The following is a description of a gene set: Binding to DNA that is assembled into chromatin. species: Mus musculus Mouse Gene Set: GOMF_CHROMATIN_DNA_BINDING, and this is the list of marker genes: Foxo3, H1f2, Ruvbl2, Rara (retinoic acid receptor, alpha), Pitx2, Actn4, Hmgn2, Tox, Hmga2, H1f10, Rxra, Wbp2nl, Crebbp, Hdac3, H1f5, Eomes, Myod1, Sbno1, Stat3, Thrb, H1f4, Bap1, Rcc1, Zfx, Pcbp2, Tox3 (TOX high mobility group box family member 3), Zfp125, Thra, Hmgn5, Ep300, Med1, Grhl2, Hr, Wbp2, Gli2, H1f0, Zfp276, Myog, Kdm6b, Zic2, Neurog3, Ahdc1, Uty, Grhl3, Top1, Hsf3, Vax1, Hmgn1, Klf4, Atoh1, Grhl1, H1f8, Foxc2, Sbno2, Nr1h2, Smad3, Nkap, Ctcfl, Cebpa, Sox2, Apex1, H1f9, Sirt6, Rxrb, Kdm3b, Vax2, Insm1, Msl2, Srf, Kdm3a, Pou5f1, Foxo1, H3f3a, Cebpb, Jmjd1c, Xbp1, Pax6, Ezh2, Lemd3, Kdm6a, Hmgn3, Dhx9, Tox4, Gata1, Vrk1, Hdac2, Macroh2a2, Lemd2, Bcl6, Ppargc1a, Zfp692, Per1, Kdm4d, Hcfc1, H3f3b, H3f5, Ddx17, H1f3, Hnrnpu, Suz12, Tbr1, Ctcf, Tox2, H1f6, Kdm5a, Runx2 (runt related transcription factor 2), Nr1h3, Mexis, Pole3 (polymerase (DNA directed), epsilon 3 (p17 subunit)), Repin1, Ogt, Rela, Atrx, H1f1, H2az1, Notch1, Macroh2a1 (NCBI Gene Id 26914), Mecp2, Prdm14, Clock, Hsf1